The following is a description of a gene set: Mouse Gene Set: GOBP_NEGATIVE_REGULATION_OF_CALCIUM_ION_TRANSMEMBRANE_TRANSPORT studied in species Mus musculus Any process that stops, prevents or reduces the frequency, rate or extent of calcium ion transmembrane transport., and this is the list of marker genes: Ubr3, Ppp3ca, Gpr35, Fbxo11, Fkbp1b, Atp1a2, Mcub, Epo, Ppp3cb, Drd4, Cav1, Cacna1f, Ucp2, Mrln, Sln, Fcrl5, 1810037I17Rik, Fmr1, Calm3, Ppp3r1, Calm1, Ahr, Ubqln1, Cbarp, Casq2, Tlr9, Smim6, Bin1, Zfas1, Rem1, Gstm7, Tgfb1, Ntsr1, Akt1, Tgfb2, Ywhae, Pkd2, Trdn, Ppp3cc, Gnb5, Pln, Ptger3, Vdac1, Sri, Bcl2, Calm2, Sestd1, Tmbim6 (transmembrane BAX inhibitor motif containing 6), Prkce, Ppp3r2, Dysf, Drd2, Gsto1